Given this list of marker genes SLC35A2, here is a description of the gene set: The human gene SLC35A2 encodes the UDP-galactose transporter. It is located on the Golgi membrane and mediates the antiport of UDP-Gal into the Golgi lumen in exchange for UMP. Nucleotide sugars such as UDP-Gal are used in protein glycosylation in the Golgi lumen. This transporter is also known to transport UDP-N-acetylgalactosamine (UDP-GalNAc) by the same antiport mechanism. Defects in SLC35A2 limit Golgi-localised pools of UDP-Gal, resulting in truncated beta-GlcNAc-terminated N-glycans and alpha-GalNAc-terminated O-glycans. Defects in SLC35A2 can cause congenital disorder of glycosylation 2M (CDG2M; MIM:300896), a disorder characterised by developmental delay, hypotonia, ocular defects and brain malformations. Congenital disorders of glycosylation (CDGs) are generally characterised by under-glycosylated serum glycoproteins and a wide spectrum of clinical features. Defects in SLC35A2 can also cause early infantile epileptic encephalopathy 22 (EIEE22; MIM:300896), a severe form of epilepsy characterised by by frequent tonic seizures or spasms beginning in infancy and accompanied by developmental problems. Reactome Pathway: Defective SLC35A2 causes congenital disorder of glycosylation 2M (CDG2M) studied in species Homo sapiens part of: SLC transporter disorders